The following is a description of a gene set: species: Homo sapiens Any anomaly of the structure of the uterus Abnormal uterus morphology Human Gene Set: HP_ABNORMAL_UTERUS_MORPHOLOGY, and this is the list of marker genes: NAB2, EPCAM, PTEN, WT1, MAD2L2, TGFB3, FANCE, PIK3CA, POLE, FH, NF2, DIS3L2, LRP2, FGF10, KLLN, SLC6A17, MCC, HPS6, TGFBR1, SMAD2, GREM1, LARS2, RPS20, HYLS1, CDH1, FANCA, AURKA, XRCC2 (X-ray repair cross complementing 2), REST, POU6F2, TP53, PTPRJ, GATA3, BAX, CCNQ, SF3B4, PMS2, POLD1, SPECC1L, PDGFRL, FANCF, PIGN, TGFBR2, COL3A1, SDHB, DLC1, CHEK2, DACT1, SDHD, TNXB, SRY, FANCM, STK11 (serine/threonine kinase 11), HNF1B, PHGDH, PPP1R12A, BRCA2, RPS6KA3, AKT1, SEC23B, RAD51C, FOXF1, RAD54B, MSH6, SEMA4A, RIPK4, DYNC2I1, AXIN2 (axin 2), DYNC2H1, ATM, SMARCB1, SETBP1, DCC, TGFB2, BMPR1A, BRIP1, FGFR2, INTU, PLA2G2A, TRIP13, AXIN1, ELN, CDC73, SALL1, ITGA8, FANCC, ALG9, COL1A1, STAT6, SDHC, CCND1, ESCO2, PMS1, COL4A5, DHCR7, FANCI, IPO8, LZTR1, GNB2, H19, RAD51, RARB, FLCN, CTNNB1, SMAD3, SRC, MLH3, TBX3, FANCD2, NDP, BUB1, FRAS1, TLR2, WDR35, KRAS, FGFR3, APC, BRCA1, GRIP1, BUB1B, FLI1, MLH1, COL5A2, SLX4, THOC6, MNX1, HOXA13, ERCC4, FZD2, FREM2, FANCL (NCBI Gene Id 55120), EP300, MSH2, COQ6, PTPN12, FANCG, MID1, IFT80, COL4A6, UBE2T, NTHL1, PALB2, WNT4, STRA6, RFWD3, USF3, BRAF, COL5A1, NRAS, TRIM28, DYNC2I2, MUTYH, FANCB, GPC3, MSH3